The following is a description of a gene set: Mouse Gene Set: REACTOME_GENE_EXPRESSION_TRANSCRIPTION studied in species Mus musculus Gene expression (Transcription), and this is the list of marker genes: Phc3, Gtf2e2, H4c4, Runx3, Blm, Pou2f2, Hnf4a, Polr3f, Cnot8, Ppp2r1a, Rbx1, Pidd1, Zfp617, Smad4, Rragb, Sgf29 (NCBI Gene Id 75565), Cited4, Nr1d1, Sgk1, Brf1, Lhb, Ywhae, Cox7b, Ints10, Cox6a1, Zfp868, H3c8, H4c3, Ints9, Zfp583, Lamtor1, H2ac4, Aurka, Ago2, Ehmt1, Zfp750, Zkscan1, Zfp385a (zinc finger protein 385A), Ppp1r13l, H2bc9, Rheb, Brpf1, Prkaa2, Vdr, Ccnt2, Zfp53, Zfp704, Mtor, Lamtor3, Usp2, H2bc13, Zfp667, Pou2f1, Nr3c1, Polr3c, Notch4, Zfp710, Dek, L3mbtl2, Prkag1, Zkscan17, Zfp30, Psmd12, Zfp87, Ccnc, Rorc, Rbbp7, Zfp582, H2ac13, Hdac8, Eaf2, Sirt3, Ercc2, Zfp169, Zfp78, Zfp61, Elf2, Zfp54, Psmc6, Rad9a, Ing5, Cox6b1, Psma4, Zfp354b, Atxn3, Prr5, Nup205, Foxo1, Pcgf5, Ywhaz, Zfp1004, Nr0b1, Zfp94 (NCBI Gene Id 22756), Kmt2b, Ppp2r1b, Smarcd1, Tada2a, Prkag3, Thrb, Ccnt1, Pbrm1, Maged1, Cpsf6, Actl6b, Mterf1b, Gatad2b, Nup62, Tada3, Zfp229, Ell3, Smad2, Mapk14, Tfap2d, Cdk4, Zfp426, Gtf2f2, Rad50 (NCBI Gene Id 19360), Gpx2, Bnip3l, Foxo6, Zkscan8, Pcna, Zfp960, Tdg, Tcf12, Nup155, Zfp12, Hdac7, Cstf3, Snrpf, Prmt6, Ssu72, H2ac6, Wdr82, Iws1, Nrbf2, Cox7a1, BC024063, Snrpd3, Nup35, Zfp383, Zfp641, Ndc1, Nr1i2, Zfp811, Taf1a, Cnot1, Zfp184, Tcf7l2, Zfp458 (NCBI Gene Id 238690), H2ac23, Cox7c, Zfp456, Zfp748, Eaf1, Zfp180, Tnks1bp1, Zfp976, Gm15446, H2bc11, Cstf2, Pou4f2, Sarnp, U2af1, Tnrc6b (trinucleotide repeat containing 6b), Gsr (glutathione reductase), Atf7ip (NCBI Gene Id 76012), Rnf111, Hipk1, Rybp, Rxra, Rbm8a, Snrpb, Zfp13, Psma3, Cul1, Ints13, Cbx6, Sp1, G6pdx, Polr1g, Ing2, Zfp141, Eed, Zfp874b, Src, Brpf3, Papola, Zfp282 (NCBI Gene Id 97311), Bax, Clp1, Prdx1, Maml3, Lef1, Zfp932, Thoc7 (THO complex 7), Ppp1r13b, Zfp563, Zfp433, Gtf3c6, Gm10053, Cga, Gps2, Ldb1, Rprd1b, Pabpn1, Ppara, Rslcan18, Ran, Akt3 (thymoma viral proto-oncogene 3), Ncor2, H2bc8, Mtf2, Rbbp5, Psmd2, Gls2, Ints8, Mnat1, Zfp472, U2af1l4, Zfp189, Zfp931, Gata2, Psmb6, Bmi1, Nr4a3, Ppp2ca, Skic8, Zfp703, Aebp2, Zkscan6, Zc3h8, Snapc2, Prdx5, Supt6, Bmal1, Cox8c, Gtf2h3, Esrrg (NCBI Gene Id 26381), Ctnnb1, Psmd8, Sin3b, Nelfcd, Rpap2 (RNA polymerase II associated protein 2), Ago4, Gtf3c5, Psmc2, H2ac8, Polr1h, Srsf3, Polr2a, Parp1, Thoc6, Taf8, Smarca4, Pgr, Gm21411, Ezh2, Psma7, H3c3, Ssrp1, Kmt5a (NCBI Gene Id 98818), Thoc2, Ctsk, Ccnb1, Hdac1, Polr3gl, Cpsf3 (cleavage and polyadenylation specificity factor 3), Ppm1a, Polr1b, Zfp867, Cdk13, Trim28, Cycs, Gtf2h4, Cbx2, Nelfb, Rrn3, Rara, Fyttd1, Pip4p1, Zfp689, Tcf7, Taf1d, Actl6a, Rffl, Zfp934, Zfp708, Supt16, Ddit4, Zfp786, Zkscan3, Mcrs1, Nbn, Eloc, Taf11, Zfp873, Cox7a2l, Snapc3, Gata3, Zfp248, Bod1l, Rbl1, Smarcc1, Yeats2, Dhx38, E2f8, Psmd1, Rbbp8, Zfp764l1, Hdac3 (histone deacetylase 3), Hdac11 (NCBI Gene Id 232232), Smurf1, Sfn, Taf1, Cdkn1a, Nup188, H3c4, Ube2d1, Smarce1, Smad1, Cdk7, Zfp696, Supt5, Mta2, Wrn, Nup58, Taf10, Dr1, Zfp97, H2ab1, Skp1, Kctd1, Polr3b (NCBI Gene Id 97660), Zfp113, Gtf2a1, Rnmt, Cox6c, Polr3k, Zfp26, Tbx5, Ogt, Supt4a, Cpsf2, H2ab2, Upf3b, Nudt21, Taf4b, Itch, Slbp, Rsl1, Ctr9, Gata1, Zfp664, Nr4a1, Rnf34, H2bc24, Ddx21 (NCBI Gene Id 56200), Rptor, Smarcd3, Smarcc2, Psmb4, Kansl2, Rmi2, Zfp975, Zfp938, Lmo1, Slc38a9, Gm14412, Tnrc6a, Nr2f1, Pax5, Ski, Suz12, Ywhab, H2bc22, Zfp317, Rnps1, Ints2, H3c1, Smarcb1, Zfp677, Tbp, Taf9, Zfp9, Lbr, Taf4 (NCBI Gene Id 98977), Rragd, Pip4k2c, Nr2e1, Tfap2c, Ttc5 (NCBI Gene Id 219022), Smad3, Usp9x, Snapc1, Tbl1xr1, Nup37, Zfp28, Nup42, Zfp268, Zfp770, Gtf3c1, Srsf7, Akt2, Zfp74, Rragc, H2bc7 (NCBI Gene Id 319180), Psma5, Ints14, Trp63, Nabp2, Noc2l, Ints6, Polr2l, Cstf1 (cleavage stimulation factor, 3' pre-RNA, subunit 1), Zfp445, Foxo3, Zfp112, Polr1f, Tgif1, Triap1, Zfp688 (NCBI Gene Id 69234), Gtf3a, Ccne1, Igfbp3, Zfp655 (zinc finger protein 655), Zfp551 (zinc finger protein 551), Prmt1, mt-Co2 (mitochondrially encoded cytochrome c oxidase II), H2bc21, Atrip, Polr3a, Psmd13, BC051665, Snapc4, Rhno1, H2ac20, Zfp735, Banp, Zfp420 (zinc finger protein 420), H2bc23, Trp73, Zfhx3, Cbx4, H3c14, Polr3g, Tigar, Arnt2, Wwtr1, Top3a (NCBI Gene Id 21975), Nr1h4 (NCBI Gene Id 20186), Ago3, Zfp997, Usp7, Alyref, Cdk5 (NCBI Gene Id 12568), Nr5a2, Cdkn1b, Topbp1, E2f4, Cdk6, Setd1a, Psmd14, Zfp386, Nup93, Wdr5, Rarg, Nr6a1, Cnot4, Zfp706, Pcgf2, Smyd2, Esrrb, Tsc2, Sirt1, Psmb1, Cdc25c, Rfc4, Brip1, Tead3, Yap1, Zfp954 (NCBI Gene Id 70514), Kat2b, Zfp606, Zfp455, Zfp69, Zfp964, Zfp760, Ercc3, Hdac10, Ice2, Zfp37, Dna2, Gls, Ppm1d, H4c16, Map2k6, Magoh, Gm5141, Psmc1, Ints12, Nup214, Bard1, Zfp354a, Zfp68, E2f5, Ints11, U2af2, Poldip3, 4930522L14Rik (RIKEN cDNA 4930522L14 gene), Zfp65, Zfp442, Zfp566, Ncbp1, Zfp27, Tal1, H4c18, Zfp804b, Smarcd2, H3c13, Cox4i2, Cavin1, Gpi1, Cpsf1, Ubc, Npas4, Sesn2, Sesn1, Zfp213, Ptpn11, Zfp839, Chd4, H4c2, Cpsf4, Psmd11, H2ac24, Foxg1, Taf2, Yeats4, H2bc26, Wdr33, Furin, Ctsl (NCBI Gene Id 320361), Ccna2, Chek2, Rabggta, Zfp963, Ywhaq, Rora, Rpa1, Polr3h (NCBI Gene Id 78929), Psma2, Zfp599, Taf5, Gm19965, Hdac5, Myc, Tfap2e (transcription factor AP-2, epsilon), Ints3, Prkaa1, Zfp235, H2ax, Tcf3, Psmc5, H4c12, Zfp619, Prmt5, Prkab2, Cbx8, Nelfe, Rad9b, Nup50, Chtop, Zfp160, Epc1, Tsc1, H3c10, Daxx, Runx2, Taf1b, Psmc3, Zfp941, Tarbp2, H2ab3 (H2A.B variant histone 3), Sumo1, Zfp267, Tfap2b, Cstf2t (NCBI Gene Id 98143), Nup85, Gtf2h1, Dyrk2, Zzz3, Sf3b1, Gtf2b, Wwox, mt-Co3, H3f3b, Polr2i, Csnk2a2, Tpr, Ints5, H2ac11 (NCBI Gene Id 319167), Cdk5r1, Ehmt2, Zfp418, Zfp2, Nr3c2, 2610021A01Rik, Ubtf, Gm4767, Nr5a1, Pip4k2a (phosphatidylinositol-5-phosphate 4-kinase, type II, alpha), Gtf2a2, Srsf2, Serpinb13, Lsm11, Psmb3, Rfc2, Mre11a, Gm32687, Rxrg, Gm3604, Auts2, Mbd3, Ipo8, Zc3h11a, Ints1, Zfp382, Rpa3, H4c17, H2ac18, Psma1, Srsf1, H4c8, Ercc6, Mamld1, Ak6, Rad1, Paf1, Ccnd1, Zfp993, Sesn3, Kat2a, Taf13, Cdk8, Srrt, Nr2c1, H2bc15, Chd3, Zfp558, Mapk11, Cdk2, Eloa, Zik1, Tead4, Ttf1, Akap8l, Kat6a, Nr1d2, Zfp595, Hdac4, Pou4f1, Gtf2h5, Rbbp4, Nup153, Zfp764, Myo1c, Rprd2, Zfp286, Zfp454, Cnot6l, Tfap2a, Zfp788, L3mbtl1, Notch3, Mdm4, Tgfb1, Zfp1007, Akt1, Zfp85, Ring1, Stk11, Jarid2, Nup107, Max, Nr2e3, Ccna1, Polr3d, Rad17, Crcp, Notch1, Zfp747, Zfp60, Chek1, Mapkapk5, Zscan25, Txnrd1, Adrm1, Foxo4, Phf20l1, Plk3, Ctcf, Cox5b, Gtf2e1, Zfpm1, Cox7a2, Gtf3c4, Psip1 (NCBI Gene Id 99979), Maml2, Ccnd3, Csnk2a1, Nup160, Higd1c, Krbox5, Zfp846, Pcf11, Tcea1, Zfp345, Cdk9, Tmem219, Kdm6a, Arid1a, Zfp273, Mapk3, Nup43, Rorb, Baz1b, Sympk, Tcf7l1, H2bc6, Ppp2cb, Paxip1, Mbip, Zfp324, Taf7, Lamtor5, Nup133, Snrpe, Sin3a, H4c6, Hcfc1, Rnf2, Ccng1, H3f3a, Ccnk, Ccnd2, Mecp2, Lsm10, Psma6, Aff4, Zfp658, Setdb1 (SET domain, bifurcated 1), Men1, Rmi1, Kansl1 (KAT8 regulatory NSL complex subunit 1), H3c6, Psmd6, Tead2, Polr1e, Cited2, Zfp711, Seh1l, Zfp398, Zfp740, Hus1, Thoc1, Pdpk1, Zfp871, Ice1, Cdc73, Uba52rt, Zfp961, Phc2 (polyhomeotic 2), Smarca5, H2ac10, Tbl1x, Polr2g, Prkab1, Nup88, Atm, Ccnh, Ell, Ash2l, Hcfc2, Cnot9, Brf2, Mllt1, Zfp39, Rfc3, Zfp872, Cnot11, Lamtor4, Sox9, Polr2c, Nr1h3, Plk2, Scmh1, Zfp612 (zinc finger protein 612), Kmt2a (lysine (K)-specific methyltransferase 2A), H3c2, Gsk3b, Polrmt, Gm6871 (NCBI Gene Id 628359), Ctdp1, H2ac7, Prkag2 (protein kinase, AMP-activated, gamma 2 non-catalytic subunit), Cenpj, Fip1l1, Nr2c2, Zfp808, Taf15, Kdm5b, E2f7, Csnk2b, Rprd1a, Ranbp2, Gtf2f1, H4c14, Rngtt, Dnmt3a, Cox6a2, Tsn, Zfp11, Ubb, Steap3, Lamtor2, Tsnax, Prelid3a, Atad2, Skil, Ube2i, Rps27a, Cpsf7, Zfp772, Nup98, Rraga, Psmb2, Psmb5, Casc3, Btg2, Pagr1a, H2az2, Zfp950, Polr2e, Zkscan7, Chm, Elob, Zfp202, Taf1c, Zfp1, Rarb (NCBI Gene Id 218772), Tasp1, Srsf11, Trp53bp2, Nedd4l, Ppp2r5c, Sec13, Phf1, Pin1, Srsf5, Jmy, Zkscan14, Bdp1, Tead1, H2bc12, Ddx39a, Zfp14, Zfp35, Psmd7, Gm14399, Npm1, Tfdp1, Gm14444, B020011L13Rik, Ar, Arnt, Nuak1, Smad7, mt-Co1, Tfb2m, Taf9b, Cdk12, Hipk2, Dnmt3b, Psmb7, Cdkn1c, Pcgf6, Yaf2, Prkra, Lmo2, Hdac6, Cnot7, Krba1, Ccne2, H4c11, Meaf6 (NCBI Gene Id 72664), Polr2k, Cox5a, Esr1, Rabggtb, Brd7, Rfc5, E2f6, Maml1, Srrm1, Psmc4, Zfp775, Ell2, Zfp605, Tgif2, H4c9, Rae1, Zfp746, H2ac12, Nr0b2, Abl1, H2ac22, Kansl3, Aaas, Thra, Ints4, Snrpg, Trp53, Mdm2 (NCBI Gene Id 69330), Ddx39b, H2bc4, Rxrb, Zfp175, Zfp937, Kmt2d, Nr1h2, Brca1, Phf20, Nabp1, Casp2, Cdk1, Taf3, Uba52, Prdx2, Kat14, Gtf2h2, Ywhah (tyrosine 3-monooxygenase/tryptophan 5-monooxygenase activation protein, eta polypeptide), Tpx2, Zfp457, Esrra, Gadd45a, Gm10778, Atp1b4, Cxxc1, Zfp712, Cox6b2, Kat8, Zfp647, Cbfb, Aurkb, Kat5, Cnot2, Ppard, Zkscan5, Polr2h (NCBI Gene Id 260309), Elf1 (NCBI Gene Id 13709), Polr2b, Phf19, Mta1, Trp53rkb, Nup210, Ago1, Nr4a2 (nuclear receptor subfamily 4, group A, member 2), Brd1, Zfp1005, Mapkap1, Zfp90, Cnot6, Rbm14, Zfp759, Rpa2, Nelfa, Zkscan16, Phc1, Zfp940, Cradd, Mllt3, Actb, Txn1, Zfp446, Gatad2a, Cnot3, Esr2, H3c11, Srsf9, Thoc3, Nup54, Pml, Ndufa4, Zfp473, Cnot10, Cox8a, Gtf3c2, Mapk1, Zkscan4, Zfp58, Phax, Ube2d3, Polr1c, Exo1, Rbpj, Ncbp2, Eif4a3, Leo1 (Leo1, Paf1/RNA polymerase II complex component), Polr2d, H2ac15, H2ac19, Tfam, Taf12, Polr2f, Polr1a, Pip4k2b, Trp53inp1, Zfp869, Zfp747l1, Zfp84, Slu7 (NCBI Gene Id 52834), Snapc5, Setd1b, Foxp3, Zfp799 (NCBI Gene Id 240064), Ints7, H2bc3, Cox4i1, Zfp974, Stub1, Nr2f6, Zfp874a, Psmd3, Zfp429, Zfp354c (NCBI Gene Id 319696), Taf6, Gtf3c3, Zfp978, H3c7, Zfp970, Med1, H2bc14, Zfp866, Cited1, Skp2 (NCBI Gene Id 75034), Nr1i3, Ep300, Zfp729a, Zfp738, Smurf2 (NCBI Gene Id 66313), Rictor, Zfp870, Mga, H3c15, Zfp212, Ywhag, Cdc40, Zfp780b, Dnmt1, H2aj, Polr3e, Prelid1, Mlst8, Zfp661, Zfp773, Zfp263, H4c1, Mybbp1a, Mta3, H2bc1, Pom121